The following is a description of a gene set: Conditional macrophage-specific PPARg knockout mice were generated on C57Bl/6 background by breeding PPARg fl/- (one allele is floxed, the other is null) and lysozyme Cre transgenic mice. PPARg and IL-4 signaling was analyzed on bone marrow-derived macrophages. Bone marrow of 3 mice per group was isolated and differentiated to macrophages with M-CSF (20 ng/ml). 20 ng/ml IL-4 was used to induce alternative macrophage activation and 1 uM Rosiglitazone (RSG) was used to activate PPARg. From each mouse 4 samples were generated: 1. M-CSF, 2. M-CSF+RSG, 3. IL-4 and 4. IL-4+RSG. All compounds were added throughout the whole differentiation process, and fresh media was added every other day. Control cells were treated with vehicle (DMSO:ethanol). After 10 days, RNA was isolated and gene expression profiles were analyzed using Mouse Genome 430 2.0 microarrays from Affymetrix. from publication Szanto A, Balint BL, Nagy ZS, Barta E, Dezso B, Pap A, Szeles L, Poliska S, Oros M, Evans RM, Barak Y, Schwabe J, Nagy L (PMID 21093321) studied in species Homo sapiens Genes down-regulated in bone marrow-derived macrophages treated with IL4 and rosiglitazone: wildtype versus PPARG knockout. Human Gene Set: GSE25123_WT_VS_PPARG_KO_MACROPHAGE_IL4_AND_ROSIGLITAZONE_STIM_DN, and this is the list of marker genes: EFHC2, LSR, XPC, TRAF5, HISLA, TTC4, MDN1, MTPAP, CPNE8, SAMD8, INPP4B, AGO2, SPAG16, CBX3, MICAL3, KMT2E, RAB21, CHM, SPIN3, PABIR2, BRD3, RPSA, RGL2, PSIP1, ATP8B4, RAI1, UBQLN2, ZFR, ARHGAP45, CROT, IL7R, FBXO11, GAB1, OGT, NR1H3, UBL4A, SUOX, WAC, TRAPPC8, EIF4G2, GATA3, SLC7A6, MICAL2, ZNF296, MCUB, FBXO42, AKAP1, ZC3H7A, DPH5 (NCBI Gene Id 51611), PRDM2, DDX3X, ATP2C1, IL2RB, DENND11, KDM5B, KLHL13, CCNG2, STAG2, ARHGAP5, GOLGA2P5, APBB3, PSEN2, SPCS3, ANKRD10, TCIRG1 (T cell immune regulator 1, ATPase H+ transporting V0 subunit a3), RFX3, LINC00467, SLC2A13, ZBTB5, GUSBP4, HAPLN3, PRMT2, TMEM38A, TTC3 (NCBI Gene Id 7267), PLCH2, DDX17 (DEAD-box helicase 17), TCP11L1, MAP3K1, EMB, PGM2L1, YWHAG, ZNF345, STAP1, DLGAP4, SNORA78, EDEM3, DENND1B, ACTR10, CEP68, MREG, TTTY14, LINC00938, XPOT, RPE, DGKE, CASP3, FBXW11, FNIP1, FXYD5, ZMAT1, BRD10, INO80D, TMEM87B, PAQR6, TNFRSF11A, SMCR8, PEX13, IL10RA, CDHR1, FAM167A, SNHG32, LEF1, CLNK, SRSF1, KDSR, EXT1, CEP97, SGSM3, MZF1, PEAK1, ABHD17B, TIE1, SUZ12, CYTH3, SVIL, FURIN, MYB, GNAI1, PALS1, MEF2D, CERNA1, PATJ, SV2A, TP53I13, LRRFIP1, GPATCH2, CDK5RAP3, TRRAP, ACAP1 (NCBI Gene Id 9744), B4GALT6 (NCBI Gene Id 9331), ZDHHC2, PLEKHF2, CLEC11A, COL4A4, USP20, ABCA7 (ATP binding cassette subfamily A member 7), WASF1, CD44, DTX1, FGFR1OP2, PYROXD2, FOXK1 (forkhead box K1), NELL2, RASA1, ZNF496, SLC20A1, GUCY1A1, CTDSP2, XCL1, NR3C1, JRK, QTRT1, SATB1, LRRC37B, ZMAT4, BMP2, ORAI2, NFKB2 (NCBI Gene Id 4791), DZIP3, PCDH9, ACVR2A, AKAP17A, APEX2, CASK, ZNF740, ZNF711, KLHL36, CEP83 (centrosomal protein 83), BRPF1 (bromodomain and PHD finger containing 1), REXO5, MDC1, DACH1, COL18A1, DOCK10, HNRNPU, RGP1, BAZ2B, SPAG1, RPGR (retinitis pigmentosa GTPase regulator), LYRM7, CELF1, FUT8, SH3YL1, NAA16, RC3H1, RAB43, KCNQ5